The following is a description of a gene set: studied in species Homo sapiens Human Gene Set: HP_CHRONIC_HEPATIC_FAILURE Chronic hepatic failure, and this is the list of marker genes: GPR35, INPP5E, MST1, HFE, ALDOB, SEMA4D, TMEM67, HADHB, CC2D2A, TCF4, HADHA, BMP6, SP110, RPGRIP1L